The following is a description of a gene set: Mouse Gene Set: GOBP_INTERLEUKIN_1_PRODUCTION The appearance of interleukin-1 due to biosynthesis or secretion following a cellular stimulus, resulting in an increase in its intracellular or extracellular levels. species: Mus musculus, and this is the list of marker genes: Ifi207, Tnfaip3, Hmgb1, Slamf9, Lilrb4b, Gorasp2, Havcr2, S1pr3, Ccr7 (NCBI Gene Id 12775), Il6 (NCBI Gene Id 16193), Tlr4, Stmp1, Panx3 (NCBI Gene Id 71631), Acp5, Sucnr1, Tnf, Nlrc3, Elf4, Nod1, Il1b (interleukin 1 beta), Nlrp12, Gas6, Gstp-ps, Spag11a, Chrna7, Il17a, Mr1, F2r, Ager, Nod2, Sphk1, Jak2, Mefv, Ighd, Serpinb1c, Ifi203-ps (interferon activated gene 203, pseudogene), Gstp1, Ifi203, Ccn1, Igf1, Casp8, Arrb2, Ripk2, Sirpa, Tmed10, Gsdma3, Pycard, Hdac3, Nlrp3, Gsdmd, Ghsr, F2rl1, Hk1, Rad21, Lpl, Stat3, Lilrb4a, Ifnar1, Lgals9, Serpinb1a, Nlrc4, Smad3, Tyrobp (TYRO protein tyrosine kinase binding protein), Egr1, Cd36, Ceacam1, Tmem106a, Ifi214, Aqp4, Pml, Lilra5, Ern1, Panx1, Gstp3, Ifi213, Cx3cl1 (NCBI Gene Id 58173), Naip5, P2rx7, Git1, Tlr2, Fzd5, Cx3cr1, Errfi1, Clec7a, Rela, Nr1h4, Mndal, Nlrp10, Ccl3, Gbp5, Myd88, Tlr6, Hspb1, Aim2, Ccl19, Arg2, Ccr5, Il16, Tlr8, Ccl20, Casp1, Cptp, Ffar1, Ptger4, Eif2ak3, Usp50, Tnfaip8, Inava, Trem2, Tmed10-ps, Casp4, Foxp1, Ifi209, Malt1, Hdac2, Panx2, Isl1, Wnt5a, Apoa1, Ffar4, Ifng, Nlrp6, Gstp2, Ifi208 (interferon activated gene 208), Ghrl, Serpinb1b, S100a13 (NCBI Gene Id 20196), App, Il1r2, Zc3h12a, Nlrp1a (NCBI Gene Id 435266), Anxa1, Ifi206, Nlrp1b